Given this list of marker genes LIAT1, TMEM253, C2CD4B, ARID1A, ZHX2, GUCY1A2, TAOK1, HSD17B3, SEMA4B, HGF, SIGMAR1, MBTPS2, TECPR2, TEAD1, RIMS4, FGF14, DISC1 (NCBI Gene Id 80138), CFL2, ZNF667, RECK, ALDH4A1, SH3GL2, ABHD4, RPH3A, CCDC177, KLHDC1, CACTIN, LPIN2, ROBO4, HOMER1, EFCAB11, KLHL15, SF3A3, MYOZ1, HOXD3, SNCAIP, JAZF1, AAR2, PTGFRN, SERPINB13, PACS1, C5orf63, RPP30, GARRE1, ZNF518B (NCBI Gene Id 85460), GSK3B, ARID1B, B3GNTL1, KLF11, DHH, SMOC2, BHMT2 (betaine--homocysteine S-methyltransferase 2), GBA2, PCDH19, TRIM14, PCDH1, MTCL2, TRIM8, STC1, EPHB1, POGZ, GULP1, CD4, SPANXN5, CCK, SHTN1, ASIC1, WIPI1, MARK2, BAHD1, ZNF548, RNMT, TXNDC17, SLC25A23, RGS6, SARM1, CABP7, GSK3A (NCBI Gene Id 2931), NID1, MMP24, here is a description of the gene set: from publication Chen Y, Wang X (PMID 31504780) Genes predicted to be targets of miRBase v22 microRNA hsa-miR-4710 in miRDB v6.0 with MirTarget v4 prediction scores > 80 (high confidence targets). species: Homo sapiens Human Gene Set: MIR4710